The following is a description of a gene set: A cell extension caused by localized decoupling of the cytoskeleton from the plasma membrane and characterized by rapid formation, rounded shape, and scarcity of organelles within the protrusion. Blebs are formed during apoptosis and other cellular processes, including cell locomotion, cell division, and as a result of physical or chemical stresses. Human Gene Set: GOCC_BLEB species: Homo sapiens, and this is the list of marker genes: ROCK1, ANLN, PANX1, P2RX7, FMNL1, SDF4, FHOD1, PTPRC, TPM1